Given this list of marker genes Fbln1, Csnk1a1, Ldb2, Sparcl1, Calr, Nrep, here is a description of the gene set: Cancer cells differentiate along specific lineages that largely determine their clinical and biologic behavior. Distinct cancer phenotypes from different cells and organs likely result from unique gene expression repertoires established in the embryo and maintained after malignant transformation. We used comprehensive gene expression analysis to examine this concept in the prostate, an organ with a tractable developmental program and a high propensity for cancer. We focused on gene expression in the murine prostate rudiment at three time points during the first 48 h of exposure to androgen, which initiates proliferation and invasion of prostate epithelial buds into surrounding urogenital sinus mesenchyme. Here, we show that androgen exposure regulates genes previously implicated in prostate carcinogenesis comprising pathways for the phosphatase and tensin homolog (PTEN), fibroblast growth factor (FGF)/mitogen-activated protein kinase (MAPK), and Wnt signaling along with cellular programs regulating such 'hallmarks' of cancer as angiogenesis, apoptosis, migration and proliferation. We found statistically significant evidence for novel androgen-induced gene regulation events that establish and/or maintain prostate cell fate. These include modulation of gene expression through microRNAs, expression of specific transcription factors, and regulation of their predicted targets. By querying public gene expression databases from other tissues, we found that rather than generally characterizing androgen exposure or epithelial budding, the early prostate development program more closely resembles the program for human prostate cancer. Most importantly, early androgen-regulated genes and functional themes associated with prostate development were highly enriched in contrasts between increasingly lethal forms of prostate cancer, confirming a 'reactivation' of embryonic pathways for proliferation and invasion in prostate cancer progression. Among the genes with the most significant links to the development and cancer, we highlight coordinate induction of the transcription factor Sox9 and suppression of the proapoptotic phospholipid-binding protein Annexin A1 that link early prostate development to early prostate carcinogenesis. These results credential early prostate development as a reliable and valid model system for the investigation of genes and pathways that drive prostate cancer. Mouse Gene Set: SCHAEFFER_PROSTATE_DEVELOPMENT_AND_CANCER_BOX2_UP Early prostate development genes (up-regulated at 6 hr dihydrotestosterone) which are also up-regulated in high grade prostatic intraepithelial neoplasia (PIN) vs invasive cancer. from publication Schaeffer EM, Marchionni L, Huang Z, Simons B, Blackman A, Yu W, Parmigiani G, Berman DM (PMID 18794802) species: Mus musculus